The following is a description of a gene set: Suppression of HMGB1-mediated inflammation by THBD Human Gene Set: WP_SUPPRESSION_OF_HMGB1MEDIATED_INFLAMMATION_BY_THBD species: Homo sapiens, and this is the list of marker genes: IKBKB, HMGB1, NFKBIA, IKBKG, RELA (RELA proto-oncogene, NF-kB subunit), CHUK, NFKB1, THBD, AGER